The following is a description of a gene set: The aggregation, arrangement and bonding together of a set of components to form a synapse. This process ends when the synapse is mature (functional). Mouse Gene Set: GOBP_SYNAPSE_ASSEMBLY studied in species Mus musculus, and this is the list of marker genes: Efnb1, Nrg2, Amigo3, Ntrk3, Lrrn3, Abi3bp, Stau2, Lhfpl4, Pclo, Adgrb2, Cdh2, Crkl, Adgrl3, Gabra6, Dvl1, Numbl, Slc12a5, Nlgn1, Nptx1, Plxna4, Lin7c, Ptprs, Numb, Slit2, Sigmar1, Elfn1, Mecp2, Gap43, Mark1, Abi3, Dock7, Sdk2, Srpx2, Ube2v2, Cntnap2, Thbs2, Efnb2, Clstn2, Sdcbp, Setd5, Tpbg, Lrrc24, Cdk5, Gabra3, Epha7 (Eph receptor A7), Flrt2, Ephb1, Nptn, Shank3, Slitrk1, Bdnf, Slit1, Pdgfb, Lats1, Lrtm2, Npas4, Lrp4, Wnt5a, Prickle2 (prickle planar cell polarity protein 2), Gsk3b, Zdhhc8, Plxna2, Slitrk3, Adgrl4, Nptxr, Lrfn3, Ntn1, Rhoa, Eef2k, Afdn, Rap2a, Dkk1, App, Srgap2 (SLIT-ROBO Rho GTPase activating protein 2), Drd2, Srcin1, Adgrb1, Lrrtm2, Plxnb3, Ppp1r9b, Hapln4, Ntng2, Dclk1, Rac1, Htr4, Plxnb1, Dock1, Adgrl1, Gpc4, Iqsec2, Eif4g1, Rtn4r, Negr1, Ptprd, Lingo2, Sema4c, Cdh9, Gabra5, Nlgn3, Ube3b, Sema4a, Ghrl, Actr3, Gabrg2, Slitrk4, Trim47, Snca, Dock4, Myo6, Psd, Dcx, Nrxn3, Arhgef15, Usp9x, Grm6, Lrit3, Cntn5, Nedd8, Farp1, Snap25, Agrn, Mycbp2, Chd4, Musk, Ptpn1, Lrtm1, Cadm1, Cdh1, Pdlim5, Plxna1, Asic2, Mdga2, Ephb2, S1pr2, Pik3r1, Shank2, Plxna3, Caskin1, Ptk2, Rab17, Lrfn4, Cacna1a, Abl1, Sptbn2, Slitrk2, Pdzd11, St8sia2, Podxl, Gabra1, Ache, Adgrb3, Fbxo45 (NCBI Gene Id 75407), Plxnb2, Gnpat, Fgfr1, Lzts3, Ube2m, Pten, Cript, Clstn3, Plxnc1, Elavl2, Zdhhc12, Sipa1l1, Lrrc4b, L1cam (NCBI Gene Id 16728), Nrxn1, Grid2 (glutamate receptor, ionotropic, delta 2), Magi2, Gabre, Adgrf1, Lin7a, Mapt, Nckipsd (NCBI Gene Id 80987), Il1rapl1, Six4, Lrrtm4, Gria1, Ptk2b, Pcdh17, Sdk1, Arhgef9, Bhlhb9, Cux2, Amigo1, Rhog, Ntrk2, Csmd2, Dbnl, Arf6, Large1, Kirrel3, Gpm6a, Iqgap1, Nrg3, Nectin3, Lingo4, Vstm5, Carmil3, Efna5, Colq, Gabra4, Sema4d, Vldlr, Dlg5, Gabrb2, Chrnb2, Lgi2, Plxnd1, Nae1 (NEDD8 activating enzyme E1 subunit 1), Oxt, Zdhhc2, Map1b, Adnp, Slitrk5, Ogt, Cbln1, Adgre5, Ppp1r9a, Fzd5, Erbb4, Lin7b, Pum2, Il1rapl2, Crtac1, Gabra2, Ntrk1, Cbln4, Slc25a46, Wnt7a, Prkca, Icam5, Arhgap33, Ctnnb1, Gabrg3, Fgf13, C1ql3, Ghsr, Dnm3, Gna13, Mdga1, Vps35 (VPS35 retromer complex component), Wnt3a, Robo1, Lrrtm1, Tlr2, Nectin1, Mef2c, Ptpn13, Cpeb3, Lrrn1, Flrt1, Fam107a, C1ql2, Srgap3, Nlgn2, Efnb3, Cyfip2, Neurl1a, Ephb3, Adgrl2, Kcnj8, Caprin1, Lrfn1, Flrt3, Syndig1, Il1rap, 2610042L04Rik, Rac3, Nrg1, Crmp1, Amigo2, Gabrb3, Gja10, Rtn4, Add2, Xlr3b (X-linked lymphocyte-regulated 3B), Slitrk6, Asic1, Bsn, Nrxn2 (neurexin II), Elmo1, Dock10, Rab29, Akap5, Reln (reelin), Cc2d1a, Lrfn5, Dlg4, Lrrtm3, Lrrc4, Cbln2, Fzd1, Oxtr, Iqsec1, Six1, Crk, Prickle1, Nlgn4l, Gabrg1, Grin1, Lzts1, Dscam, Clstn1, Igsf11